Given this list of marker genes Mapk1, Abl1, Mapk3, Ttc21b, Ptpn11, Abl2, Gpr37l1, Plpp3, Shh, Map2k1, Gfap, Vim, here is a description of the gene set: The process in which neuroepithelial cells of the neural tube give rise to Brgmann glial cells, specialized bipotential progenitors cells of the cerebellum. Differentiation includes the processes involved in commitment of a cell to a specific fate. studied in species Mus musculus Mouse Gene Set: GOBP_BERGMANN_GLIAL_CELL_DIFFERENTIATION